The following is a description of a gene set: Human Gene Set: GOCC_MULTIMERIC_RIBONUCLEASE_P_COMPLEX A ribonuclease P complex that generally contains a single RNA molecule and several protein molecules. Examples of this complex are found in Archaeal species. species: Homo sapiens, and this is the list of marker genes: RPP40, POP4, RPP25, RPP21, RPP38, RPP14, RPP30, POP5 (NCBI Gene Id 51367), POP7, POP1